Given this list of marker genes TCIRG1, KRAS, G6PC3, GFI1, CLPB, PIK3CD, ARPC5, SRP68, NRAS, ELANE, SEC61A1 (NCBI Gene Id 83289), DDX41, IKBKB, ZNFX1, SRP19, here is a description of the gene set: Abnormal increase of absolute number of monocytes in the blood, per microlitre, compared to a reference range for a given sex and age-group. studied in species Homo sapiens Human Gene Set: HP_INCREASED_TOTAL_MONOCYTE_COUNT Increased total monocyte count